Given this list of marker genes Wdr3, Wdr36, Pwp2, Utp6, Utp18, here is a description of the gene set: Mouse Gene Set: GOCC_PWP2P_CONTAINING_SUBCOMPLEX_OF_90S_PRERIBOSOME A protein complex that forms a subcomplex of the 90S preribosome and can interact directly with the 5' External Transcribed Spacer (ETS) of the full length pre-rRNA transcript. In S. cerevisiae, it sediments at 25-30 S and is composed of Pwp2p, Dip2p, Utp21p, Utp13p, Utp18p, and Utp6p. studied in species Mus musculus